The following is a description of a gene set: Upregulation of HER2/ErbB2/Neu occurs in 15-30% of human breast cancers and correlates with poor prognosis. Identification of ErbB2/Neu transcriptional targets should facilitate development of novel therapeutic approaches. Development of breast cancer is a multistep process; thus, to identify the transcriptomes associated with different stages of progression of tumorigenesis, we compared expression profiles of mammary tumors and preneoplastic mammary tissue from MMTV-Neu transgenic mice to expression profiles of wild-type mammary glands using Affymetrix microarrays. We identified 324 candidate genes that were unique to ErbB2/Neu-induced tumors relative to normal mammary gland tissue from wild-type controls. Expression of a subset of these genes (82) was also changed in the preneoplastic mammary glands compared to wild-type controls, indicating that they may play a pivotal role during early events of ErbB2/Neu-initiated mammary tumorigenesis. Further analysis of the microarray data revealed that expression of several known transforming growth factor (TGF)-beta target genes was altered, suggesting that the TGF-beta signaling cascade is downregulated in ErbB2/Neu-induced tumors. Western blot analysis for TGF-beta-Receptor-I/ALK5 and immunohistochemistry for TGF-beta-Receptor-I/ALK5 and phosphorylated/activated Smad2 confirmed that the Smad-dependent TGF-beta signaling cascade was inactive in these tumors. Although absent in most of the tumor, phosphorylated Smad2 was present in the periphery of tumors. Interestingly, presence of phosphorylated/activated Smad2 correlated with expression of Activin-Receptor-IB/ALK4, suggesting that although Smad-dependent TGF-beta signaling is absent in ErbB2/Neu-induced tumors, Activin signaling may be active at the leading edge of these tumors. Cumulatively, these data indicate that the TGF-beta pathway is intrinsically suppressed in ErbB2/Neu tumors via a mechanism involving loss of TGF-beta-Receptor-I/ALK5. Down-regulated genes from top genes out of the 324-gene signature identified in the pre-neoplastic tissue adjacent to the mammary tumors induced by transgenic expression of ERBB2. species: Mus musculus from publication Landis MD, Seachrist DD, Montañez-Wiscovich ME, Danielpour D, Keri RA (PMID 15897883) Mouse Gene Set: LANDIS_ERBB2_BREAST_PRENEOPLASTIC_DN, and this is the list of marker genes: Nr1h3, Htra1, Scp2, Cidec, Mccc1, Sowahc, Ghr, Cxcl12, Chpt1, Gyg1, Cpt2, Npc2, Ndufab1, Eif4ebp1, Col6a3, Jchain, Gbe1, Abhd5, Ces1d, Gpd2, Ptprb, Adipor2, Tmem43, Adrb3, Etfb, Igfbp6, Dhrs7, Uck1, Mknk2, Ppp2r5a, Atp1b3, Ndufv1, Bckdhb, Decr1, Penk (NCBI Gene Id 18619), Dgat1, Gpx3, Aldh1a7, St3gal6, Aplp2, Gstz1, Gdpd3, Pdha1, Cd36, Pgm1, Acaa1a, Acaa2, Lpin1, Chchd10, Hadhb, Rab34, Gnai1, Bcat2, Uqcr10, Alad, Gpam, Zfp703